Given this list of marker genes CDK6, NUMBL, KDM2B, ANP32B, MBOAT7, DNAH5, ATP1B2, HYDIN, MNAT1, TTC21B, NME5, RAPGEF2, TSKU, WDR89, NUMB, KIF27, CENPF, MYH10 (NCBI Gene Id 4628), CELSR2, CORO1C, C12orf57, DPCD (NCBI Gene Id 25911), CCDC134, RPGRIP1L, PAX5, SEMA6D, BBS4, BBS1, AQP1, ODAD2, UCHL5, MECP2, AK8 (NCBI Gene Id 158067), SLC7A11, here is a description of the gene set: Human Gene Set: GOBP_VENTRICULAR_SYSTEM_DEVELOPMENT studied in species Homo sapiens The process whose specific outcome is the progression of the brain ventricular system over time, from its formation to the mature structure. The brain ventricular system consists of four communicating cavities within the brain that are continuous with the central canal of the spinal cord. These cavities include two lateral ventricles, the third ventricle and the fourth ventricle. Cerebrospinal fluid fills the ventricles and is produced by the choroid plexus.